The following is a description of a gene set: species: Homo sapiens Human Gene Set: GOMF_PROTEIN_TYROSINE_KINASE_INHIBITOR_ACTIVITY Stops, prevents or reduces the activity of a protein tyrosine kinase., and this is the list of marker genes: LILRB4, IBTK, PTPRC, CAV1, HYAL2, SOCS3, RACK1, CEP43, DUSP3, DUSP22